Given this list of marker genes Glul, Zdhhc14, Zdhhc21, Zdhhc6, Zdhhc25, Dlat, Zdhhc12, Ykt6, Zdhhc13, Fasn, Zdhhc16, Zdhhc3, Mcat, Zdhhc9, Zdhhc17, Zdhhc2, Zdhhc11, Zdhhc18, Dlst, Zdhhc22, Zdhhc1, Zdhhc15, Zdhhc24, Zdhhc5, Zdhhc7, Zdhhc20, Zdhhc23, Zdhhc19, Zdhhc4, Zdhhc8, here is a description of the gene set: Catalysis of the transfer of an acyl group to a sulfur atom on the acceptor molecule. species: Mus musculus Mouse Gene Set: GOMF_S_ACYLTRANSFERASE_ACTIVITY